The following is a description of a gene set: Human Gene Set: LIANG_SILENCED_BY_METHYLATION_UP studied in species Homo sapiens Hypermethylation of the promoters of cancer-related genes is often associated with their inactivation during tumorigenesis. Several preclinical and clinical trials have been developed to use DNA methylation inhibitors, such as 5-aza-2'-deoxycytidine (5-Aza-CdR) in attempts to reactivate silenced genes in human cancers. We used high-density oligonucleotide gene expression microarrays to examine the effects of 5-Aza-CdR treatment on human fibroblast cells (LD419) and a human bladder tumor cell line (T24). Data obtained 8 days after recovery from 5-Aza-CdR treatment showed that more genes were induced in tumorigenic cells (genes induced; >or=4-fold) than nontumorigenic cells (genes induced; >or= 4-fold). Approximately 60% of induced genes did not have CpG islands within their 5' regions, suggesting that some genes activated by 5-Aza-CdR may not result from the direct inhibition of promoter methylation. Interestingly, a high percentage of genes activated in both cell types belonged to the IFN signaling pathway, confirming data from other tumor cell types. Genes up-regulated in LD419 cells (fibroblast) after treatment with decitabine (5-aza-2'-deoxycytidine). from publication Liang G, Gonzales FA, Jones PA, Orntoft TF, Thykjaer T (PMID 11861364), and this is the list of marker genes: MFAP5, ASAH1, LAMC2, ANXA8, MYH3, MMP3, SCG5, ALDH1A3, LGMN, KRT17, COX7A1, SRGN, MAGEA4, KRT19, H2AC6, IFI27, C3, TIMP3, PF4V1, SAA1, KRT7, H2BC21, KRT8, H2BC6, TNFSF4, AQP1, STAT1, H19, OLR1, CCND2, PAPPA, ANXA3, CHI3L1 (chitinase 3 like 1)